The following is a description of a gene set: studied in species Mus musculus Genes selectively expressed by cells fated to differentiate as corticothalamic projection neurons in embryonic day 14.5 mouse cortex. Mouse Gene Set: HEVNER_CORTEX_COMMITTED_TO_CORTICOTHALAMIC_PROJECTION_NEURON_FATE from publication Bedogni F, Hevner RF (PMID 34321999), and this is the list of marker genes: Cntnap2, Tbr1, Slc4a10, Mgll, St18, Wnt7b, Mdga2, Neto2, Tle4, Gria3, Nfe2l3, Ngfr, Hpca, Smarcd3, Ppp1r1b, Cnih3, Pde9a, Cacna1e, Mmp17, 6430548M08Rik, Zfpm2, Camk4, Adamts18, Pcnx1, Necab3